The following is a description of a gene set: NOTCH2 intracellular domain regulates transcription studied in species Homo sapiens Human Gene Set: REACTOME_NOTCH2_INTRACELLULAR_DOMAIN_REGULATES_TRANSCRIPTION, and this is the list of marker genes: CREB1, NOTCH2, MAML1 (mastermind like transcriptional coactivator 1), HES5 (hes family bHLH transcription factor 5), MAMLD1, MAML3, EP300, HES1, RBPJ, MAML2, GZMB, FCER2